The following is a description of a gene set: The chemical reactions and pathways involving glyceraldehyde-3-phosphate, an important intermediate in glycolysis. Human Gene Set: GOBP_GLYCERALDEHYDE_3_PHOSPHATE_METABOLIC_PROCESS studied in species Homo sapiens, and this is the list of marker genes: RPEL1, SLC25A10, RPIA, TKFC, ALDOB, PCK1 (NCBI Gene Id 5105), SHPK (sedoheptulokinase), TPI1, GLYCTK, RPE, TALDO1, TKT